The following is a description of a gene set: studied in species Homo sapiens Human Gene Set: HP_RHEUMATOID_FACTOR_POSITIVE The presence in the serum of an autoantibody directed against the Fc portion of IgG. Rheumatoid factor positive, and this is the list of marker genes: IFNGR1, RIPK1, LYN, CASP10, FAS, PTPN22, CYBC1, CIITA, FASLG, NFKBIL1, DOCK11, STING1, IL10, SLC22A4, CARD10, CCN6, PGM3, C1QB, CD244, HLA-B